Given this list of marker genes CD86, ENTPD4, SLC4A10, USF3, NPR3, DOCK4, CLOCK, SMAD2, YAP1, ASPH, ABRACL, RLIG1, TMEM260, ERICH1, GPHN, TSPAN2, PAIP1, PDP1, TMEM9B, SPIRE1, CARD8, GRIA2, TMEM59, DMD, ACBD3, HIPK3, UBE2Q2, S100Z, LRRC1, MTX2, SPP1, MZT1, NEDD4, BRINP3, GUCY1A2, GOLPH3 (golgi phosphoprotein 3), TMEM170B, KPNA1, PGM2, NSL1, TNFAIP6, IRX2, SPDYA, TOPORS, KAT6A, RAB5B, DPY19L2, SLITRK4, LCT, REEP1, BAZ2B, PTBP3, SLC24A4, ZFP1, TAX1BP1, NLN, ZIC3, WWC2, RERE, ZBTB6, WDR20, CEP97, HSCB, MTSS1, NPAS3, PPP2R5E, EIF2S1, ARMC8, DYNC2LI1, CTNNA2, PPP4R1, GPATCH2L, MOSPD1, YIPF6, FUT9, DTD2, MYO16, WDCP, BNIP2, FAM107B, CACNB4, SLAMF7, ADH5, ZNF608, GABRG2, AGFG1, ELAPOR2, ABCE1, CMTR2, SLC37A3, LYZ, AKR1C4, CXCL12, DEPDC1, DMC1, FAR1, ZNF300, RALA, GAB2, UBQLN1, PREPL, ETNK1, GAD1, NEMF, CA8, DDX60L, SLC25A13, DLG5, SMURF2, CHD6, GALNT3, USP46, BMI1, COMMD3-BMI1, SYT4, ODC1, ZNF24, SEL1L, HGF, PHLPP1, YPEL2, TAFA5, HMCN1, LRP12, BNIPL, YTHDF3, PPFIA2, ISG20, PCMTD1, PCGF5, F9, HS6ST2, EXTL2, TRIM66, AZI2, LIN28A, ZDHHC21, PLD5, MIER3, STAG2, PABIR3 (NCBI Gene Id 159091), ZNF680, CRNKL1, EFR3A, CAVIN4, FAM149A, PIAS2, FIRRM, KLHL8, MRPL19, GABRB2, EXOC6B, PRTG, PURB, ALOX12, FAM120C, REL, MKRN1 (NCBI Gene Id 392799), FLT1, STOX1, ACSL4, MRS2 (NCBI Gene Id 63855), IL1RN, SENP8, RUFY2, here is a description of the gene set: Human Gene Set: MIR520E_5P Genes predicted to be targets of miRBase v22 microRNA hsa-miR-520e-5p in miRDB v6.0 with MirTarget v4 prediction scores > 80 (high confidence targets). species: Homo sapiens from publication Chen Y, Wang X (PMID 31504780)